Given this list of marker genes Nmrk1, Nmrk2, Nmnat2, Nadk2, Nampt, G6pdx, Slc25a51, Nadk, Idh2, here is a description of the gene set: The chemical reactions and pathways resulting in the formation of nicotinamide adenine dinucleotide phosphate (NADP+), a coenzyme that interconverts with its reduced form, NADPH, in many redox and biosynthetic reactions. studied in species Mus musculus Mouse Gene Set: GOBP_NADP_BIOSYNTHETIC_PROCESS